The following is a description of a gene set: Autophagy Human Gene Set: WP_AUTOPHAGY species: Homo sapiens, and this is the list of marker genes: ATG13, MAP1LC3B, DEPTOR (NCBI Gene Id 64798), MTOR (mechanistic target of rapamycin kinase), ATG101 (NCBI Gene Id 95005), ATG3, PRKAA2, WIPI2, PRKAB2, ATG9A, MLST8, ATG12, UVRAG, ATG5, PRKAB1, AMBRA1, PRKAG3, PRKAG2, ATG14, PRKAA1, ATG16L1, PIK3C3, PRKAG1 (protein kinase AMP-activated non-catalytic subunit gamma 1), RPTOR, RB1CC1, AKT1S1, ATG7, PIK3R4, ULK1, BECN1 (NCBI Gene Id 8678, beclin 1)